The following is a description of a gene set: Mouse Gene Set: GOBP_REGULATION_OF_POTASSIUM_ION_TRANSMEMBRANE_TRANSPORT Any process that modulates the frequency, rate or extent of potassium ion transmembrane transport. studied in species Mus musculus, and this is the list of marker genes: Kcnj2, Wnk1, Kcnn2, Wnk2, Nr3c2, Rgs4, Akap6, Lrrc38, Nppa, Lrrc55, Kcnip2, Amigo1, Cacna1d, Ank3, Itgb1, Ywhae, Sumo1, Cav3, Kel, Ank2, Rgs7, Kcne2, Kcnrg, Kcng1, Dpp6, Kcnh2, Cd63, Oprk1, Kcnmb1, Kcnab1, Abcc9, Gal, Kcng4, Wwp2 (NCBI Gene Id 66894), Nedd4l, Lrrc52, Akap9, Atp1b1, Prnp, Rnf207, Kcne5, Gnb2, Crbn, Bin1, Flna, Kcnab3, Lrrc26, Kcns2, Kcns1, Wnk3, Ano6, Edn3, Kcnab2, Actn2, Kcnip4, Kcnip3, Wnk4, Kcnc2, Atp1b2, Kcnq1, Kcne1, Kcng3, Grp, Oxsr1, Atp1b3, Casq2, Kcne3, Dpp10, Agrn, Fhl1, Neto1 (neuropilin (NRP) and tolloid (TLL)-like 1), Nedd4, Ptger3, Kcnip1, Stk39, Kcnc1, Cav1, Dlg1, Akap7, Kcnj1, Galr2, Vamp2